Given this list of marker genes Ttk, Spdl1, Cenph, Cenpe, Clasp1, Mad1l1, here is a description of the gene set: Mouse Gene Set: GOMF_KINETOCHORE_BINDING Binding to a kinetochore, a proteinaceous structure on a condensed chromosome, beside the centromere, to which the spindle fibers are attached. studied in species Mus musculus